The following is a description of a gene set: Mouse Gene Set: GOBP_POSITIVE_REGULATION_OF_BONE_RESORPTION studied in species Mus musculus Any process that activates or increases the frequency, rate or extent of bone resorption., and this is the list of marker genes: Ptger4, Src, Tfrc, Fcgr4, Ppargc1b, Adam8, Syk, Dlk1, Fshb, Lrp6, Spp1, Trf, Car2, Plekhm1, Ltbp3, Rufy4, Def8, Oscar, Mc4r, Tnfsf11, Dcstamp, Ahsg, Tmem64, Prkca, Tnfrsf11a, Egfr, Idua, Itgb3